The following is a description of a gene set: species: Homo sapiens Any process that activates or increases the frequency, rate or extent of supramolecular fiber organization. Human Gene Set: GOBP_POSITIVE_REGULATION_OF_SUPRAMOLECULAR_FIBER_ORGANIZATION, and this is the list of marker genes: WDR1, DCTN1, SDC4 (NCBI Gene Id 6385), EPHA1, MTSS1, PSEN1, FCHSD1, ARL2, SMAD3, PTK2B, FHOD1, TESK1, CTTN, LIMK1, SPAST, LIMCH1, MYOC, GSN, COLGALT1, NPHS1, STMN2, PFN3, BRAF, ARHGEF10, APOE, VIL1, TGFBR1, MLST8, PDE4DIP, SORBS3, NCKAP1L, CSF3, SCIN, GIT1, LMOD1, PYCARD, ARHGEF10L, CRACD, PAK1 (p21 (RAC1) activated kinase 1), CFL1, BAIAP2, CCL24, PSRC1, KATNB1, USP8, OCLN, SKA1, ABL1, PRKCE (NCBI Gene Id 5581), F2RL1, BMP10, SLAIN2, RB1, S100A10, CCL11, EVL, BIN1, MECP2, MAGEL2, TRIM27, RHOC, CCDC88A, RAC1, CDK5RAP2, LMOD2, PRKD1, SFRP1, FCHSD2, CX3CL1, CDC42EP3, MET, PXN, NF2, PFN1, NCK1, NAV3, SEMA5A, CFL2, PLEK, FER, CLIP1, LPAR1, GPX1, ARHGEF15, TACR1, ARHGEF5, SYNPO2, C15orf62, TAC1, RPS3, NUMA1, ALOX15, ITGB1BP1, MIR1-1, APP, CCN2, KIRREL1, TNXB, HCK, EDN1, APOA1, TOGARAM1, NRP1 (neuropilin 1), HSPA1A, SLAIN1, CDC42EP2, EFEMP2, ROCK2, DRG1, VASP (vasodilator stimulated phosphoprotein), RAPGEF3, AKAP9, PDXP, CDC42EP4, WNT4, SNX9, WASHC2C, TENM1, RHOA, CKAP5, PROX1, WASF3, BAIAP2L2, CDC42EP1, TRPV4, CCL26, CCR7 (NCBI Gene Id 1236), TPM1, PPM1F, CD47, ARPC2, FERMT2, CDKN1B, WASF1, NCK2, CCL21 (C-C motif chemokine ligand 21), CDC42EP5, AURKB, ANKRD53, SYNPO2L (NCBI Gene Id 79933), WHAMM, MYLK3, CLU, PFN2, MTOR, CARMIL2, PPM1E (protein phosphatase, Mg2+/Mn2+ dependent 1E), SERPINF2, CYFIP1, CDK5R1, FES, RGCC, GPR65, CDC42, HSPA1B, GRB2, BAIAP2L1, WASF2, CLASP1, ACTN2, AMOT, ARF6, DSTN, CAV3, TGFB3, ABI2, BRK1, MAP1B, BAG4, SWAP70, RICTOR, MAPT, NCKAP1, MAPRE1, SYNPO, DLG1, CARMIL1, FLNA